Given this list of marker genes SALL1, GATA3, LIF, DSG2, BASP1, SIX2, SMO, STAT1, PAX8, GREM1 (NCBI Gene Id 7947), WNT9B (NCBI Gene Id 7484), PELO, CITED1, FZD7, GDNF, PAX2, WNT4, TCF15, CTNNB1, WT1, here is a description of the gene set: species: Homo sapiens A transition where a mesenchymal cell establishes apical/basolateral polarity, forms intercellular adhesive junctions, synthesizes basement membrane components and becomes an epithelial cell. Human Gene Set: GOBP_MESENCHYMAL_TO_EPITHELIAL_TRANSITION